Given this list of marker genes HORMAD1, LIF, ESPL1, CDC23, ZWILCH, SMPD3, RAD21, BUB1, ANAPC11, CHEK1, DRD3, NANOS2, PDE3A, SPHK1, GPR3, INS, UBE2B, DAPK3, EDN3, CUL9, SPC24, OOEP, PLK1, PDGFB, AURKA, NPM2, CDC42, DLGAP5, ZW10, EGF, KLHL22, ATM, CENPF, L3MBTL1, SKA3, HOXA13, NUP62, BIRC5, SKA1, SPDL1, RB1, FBXO43, BTC, HASPIN, PKMYT1, PRDM9, WNT5A, ZNF207, PRP4K, PLCB1, NPR2, PIN1, ANAPC7, CALR, ANAPC15, FBXW5, MAD1L1, RAD51AP1, BORA, EPGN, STRA8, RAD1, IK, CCDC8 (NCBI Gene Id 83987), MSX2, FBXO5, GEN1, BUB1B, CDC20, SH2B1, BMP4, NSMCE2, IGF2, UBE2C, PSMG2, PRMT5, SPC25, MAD2L2, TNF, ANAPC5, MOS, KIF20B, NUF2 (NCBI Gene Id 83540), DMRT1, RPS6KA2, CD28, OBSL1, NDC80, AURKAIP1, XRCC3, KNTC1, APC, NEK2, BMP7 (NCBI Gene Id 655), TTK (TTK protein kinase), NUSAP1, PDXP, EDN1, TOM1L1, SIRT2, MKI67, CUL7, MTBP, CAV2, PRAP1, WNT4, CDC25C, BUB3, CUL3, IL1B, PIWIL2, MAD2L1, PSMA8, LRP5, TGFA, DUSP1, RCC1, TRIP13, FZR1, EREG, DAZL, CDCA2, INSR, IL1A, CDCA8, FGF8, CDK5RAP2, KNL1, INCENP, MSX1, LCMT1, PDGFRB, NFE2L1, DYNC1LI1, TPR, IGF1, CDC16 (cell division cycle 16), MEIOSIN, TEX14, USP44, AURKB, PHIP, CCNB1, NME6, WEE2, TOM1L2, MAD2L1BP, ZWINT, here is a description of the gene set: species: Homo sapiens Any process that modulates the frequency, rate or extent of nuclear division, the partitioning of the nucleus and its genetic information. Human Gene Set: GOBP_REGULATION_OF_NUCLEAR_DIVISION